Given this list of marker genes NPPC (NCBI Gene Id 4880), GUCA1ANB-GUCA1A, KCNC2, GUCY2D, NHERF4, KDR, NPPB, CD36, PDE3A, GUCY1A2, GUCY1B1, APOE, PDE10A, ATP2B4, HTR2C, THBS1, NPR1, GUCY1A1, PDE2A, NPPA, PDE11A, RUNDC3A (NCBI Gene Id 10900), PRKG1, CGAS, GUCA1A, GUCA2B, EDNRB, AGTR2 (angiotensin II receptor type 2), HTR2B, AQP1, GUCY2F, ADORA2B, AGT, ADNP, MTNR1B, IRAG1, INS, here is a description of the gene set: Human Gene Set: GOBP_CGMP_MEDIATED_SIGNALING An intracellular signaling cassette that starts with production of cyclic GMP (cGMP), and ends with activation of downstream effectors that further transmit the signal within the cell. studied in species Homo sapiens